The following is a description of a gene set: from publication Gouyer V, Fontaine D, Dumont P, de Wever O, Fontayne-Devaud H, Leteurtre E, Truant S, Delacour D, Drobecq H, Kerckaert JP, de Launoit Y, Bracke M, Gespach C, Desseyn JL, Huet G (PMID 18317448) Human Gene Set: GOUYER_TATI_TARGETS_UP Genes up-regulated in constitutively invasive HT-29 5M21 cells (colon cancer) vs those expressing functionally inactive TATI. species: Homo sapiens From the conditioned medium of the human colon carcinoma cells, HT-29 5M21 (CM-5M21), expressing a spontaneous invasive phenotype, tumor-associated trypsin inhibitor (TATI) was identified and characterized by proteomics, cDNA microarray approaches and functional analyses. Both CM-5M21 and recombinant TATI, but not the K18Y-TATI mutant at the protease inhibitor site, trigger collagen type I invasion by several human adenoma and carcinoma cells of the colon and breast, through phosphoinositide-3-kinase, protein kinase C and Rho-GTPases/Rho kinase-dependent pathways. Conversely, the proinvasive action of TATI in parental HT29 cells was alleviated by the TATI antibody PSKAN2 and the K18Y-TATI mutant. Stable expression of K18Y-TATI in HT-29 5M21 cells downregulated tumor growth, angiogenesis and the expression of several metastasis-related genes, including CSPG4 (13.8-fold), BMP-7 (9.7-fold), the BMP antagonist CHORDIN (5.2-fold), IGFBP-2 and IGF2 (9.6- and 4.6-fold). Accordingly, ectopic expression of KY-TATI inhibited the development of lung metastases from HT-29 5M21 tumor xenografts in immunodeficient mice. These findings identify TATI as an autocrine transforming factor potentially involved in early and late events of colon cancer progression, including local invasion of the primary tumor and its metastatic spread. Targeting TATI, its molecular partners and effectors may bring novel therapeutic applications for high-grade human solid tumors in the digestive and urogenital systems., and this is the list of marker genes: ZBTB16, PRKCA, PLD1, TFF3, LCN2, CCL2, CXCL8, ID2, ANPEP, TNF